The following is a description of a gene set: studied in species Homo sapiens from publication Cui Y, Zheng Y, Liu X, Yan L, Fan X, Yong J, Hu Y, Dong J, Li Q, Wu X, Gao S, Li J, Wen L, Qiao J, Tang F (PMID 30759401) Human Gene Set: CUI_DEVELOPING_HEART_C2_CARDIOMYOCYTE, and this is the list of marker genes: NEBL, SH3RF2, PTP4A3, LDB3, MLF1, PPP1R1A, SLC25A4, MYH7, MYL3, TTN (titin), ALDOC, MTUS2 (NCBI Gene Id 23281), MDH1, CHCHD10, ACTN2 (actinin alpha 2), PPP1R14C, BNIP3, CKM, EIF1B, TNNC1, MYOZ2, MYL4, NDUFS6, HSPB3, PFKP (phosphofructokinase, platelet), MYL7, DES, PPP1R12B, TCAP, FITM1, IDH2, SLC8A1, NMRK2, RBM24, NPPA, MB, HSPB2, PGAM2, ANKRD1, POPDC2, POPDC3, COX6A2, TNNT2, SMYD1, MYOM1, SORBS2, RRAD, TRIM55 (NCBI Gene Id 84675), ATP5MC1, ADPRHL1, SYNPO2L, COX5A, MYZAP, CRYAB, CKMT2 (creatine kinase, mitochondrial 2), CSRP3, MYH6, TRDN, SNTA1, FHL2, TNNI1, LRRC10, CISD1, LINC00881, NEXN, FGF12, GOT1, PPP1R3C, NKX2-5, PLN, TECRL, CFL2, COX7A1 (NCBI Gene Id 1346), MYBPC3, APOBEC2, HACD1, ENO3, MYL9, ACTC1, HSPB7, BANCR, FABP3, PDLIM5, MYLK3, MAP3K20, CRIP2, UNC45B, TNNI3, PDE4DIP, SH3BGR, SMPX